The following is a description of a gene set: Many symptoms associated with allergic asthma result from the sequelae of type 2 inflammation. Interleukin (IL)-25 promotes type 2 inflammatory responses, and T2M cells represent an IL-4 and IL-13 producing granulocytic IL-25 responsive population. We used microarrays to characterize the gene expression profile of T2M cells, and compared T2M cells to other inflammatory subsets (eosinophils, neutrophils, and macrophages) in the lungs of mice with IL-25-induced pulmonary inflammation. from publication Petersen BC, Budelsky AL, Baptist AP, Schaller MA, Lukacs NW (PMID 22543263) Human Gene Set: GSE36392_TYPE_2_MYELOID_VS_NEUTROPHIL_IL25_TREATED_LUNG_DN Genes down-regulated in comparison of type 2 myeloid (T2M) cells treated with IL25 versus neutrophils treated with IL25. studied in species Homo sapiens, and this is the list of marker genes: FBXO34, GMPPA, NDUFS2, WDR55, EMB, VCAN, ACAD8, ZDHHC7, ALDH1B1, MAGED1, RPL17, TNFRSF21, PACS2, UBE2G2, REEP4, DNAJC16, ETV6, AP1B1, AMZ1 (NCBI Gene Id 155185), MRPL18, FAM89B, TIFAB, TSPAN33, SEPTIN9, SEC61G (NCBI Gene Id 23480), NOP2, FOXRED2, PLBD1, TRIM36, AUH, NAP1L1, RASGRP1, TYSND1, BHLHE40, MRS2, UBALD2, CCS, NDUFB10, FKBP5 (NCBI Gene Id 2289), HEMK1, SDC1, AIRIM, HINT2, GPR19, G6PD, UBE2K, RCC1L, PIGA, C19orf47, FAM234B, FAM117B, IRF7, ANKRD40, TOMM40, GTF3C6, AURKAIP1, RPL35, DRC1, TNFRSF12A (TNF receptor superfamily member 12A), SCN4B, TM4SF5, FLT1, LCMT1, ANKRD31, PPM1G, MSR1, ZDHHC9, SERPINB4, FAM72A, MED7, IDH3A, CATSPER2, NUDT15, MRPS7, TRIO, PHF23, AHCY, NLE1, USP18, SH2B2, RPL24, CYC1, PLIN2, ARL6, VHL, CCR2, EIF3D, NUDT9, UNC93B1, TOP2A, CREB3L2, ZMAT5, NFIL3 (NCBI Gene Id 4783), IFNGR1, ORAI1, PMPCA, LONP1, ITPRIPL1, EXTL3, PIEZO1, SLC5A2, H2AJ, STOML2, ADGRV1, MYEF2, CARM1, SIRT4, PGAM1, PSMC1, CENPF, HLCS, KDM7A, TMEM51, GBF1, GDF3, NR4A2, NELFA, TBC1D13, BCKDHA, AARS1, F10, CNOT8, HTR7, TUBA1B, CWC15, PFKP, PARP9, GNPAT (NCBI Gene Id 8443), KCTD5, PALLD, ADARB2, RAVER1, SLC27A3, TNFRSF11A, PPP5C, CTSB, UXT, HNRNPA1, NDUFS6, ATF6B, IMP4, STAMBP, ALG5, SYNRG, MDP1, RLN1, AUP1, PDRG1, HS3ST3B1, VPS26B, ZNHIT3, ABI3, CENPE, CHMP6, PSMB7, DDRGK1, PLOD3, GTF3A, MGMT, UBA1, NDUFA9, MAOB, ADGRG5, FAM86B2, RAD23A, ARHGEF6, CDC42EP4, RPL19, MATK, IFI44L, RARB, PLXDC1, GORASP2, ICMT, OTULINL, KIF20A, GNGT2, SAP18, RAMP1, COA7, TAPBPL, FYTTD1, MRPS18A, RPS23, CERK, RCC2, MRPS28, DET1, NDUFS5 (NCBI Gene Id 4725), RPL9, NCOA5, MTG1, KAT2A, GSTM5, RUNX3 (NCBI Gene Id 864), PYM1, IL6ST, POLR1A, EDEM1, CD300LD